Given this list of marker genes NR0B1, KCNQ1OT1, CDKN1C, IGF2, KCNQ1, here is a description of the gene set: Human Gene Set: HP_ADRENOCORTICAL_CYTOMEGALY The presence of large polyhedral cells with eosinophilic granular cytoplasm and enlarged nuclei in the adrenal cortex. species: Homo sapiens Adrenocortical cytomegaly